Given this list of marker genes B3galt5 (NCBI Gene Id 93961), B3galnt1, B3galt4, B3galt2, B3galt1, here is a description of the gene set: Catalysis of the reaction: an N-acetyl-beta-D-glucosaminyl derivative + UDP-alpha-D-galactose = a beta-D-galactosyl-(1->3)-N-acetyl-beta-D-glucosaminyl derivative + H+ + UDP. Mouse Gene Set: GOMF_N_ACETYL_BETA_D_GLUCOSAMINIDE_BETA_1_3_GALACTOSYLTRANSFERASE_ACTIVITY studied in species Mus musculus